Given this list of marker genes HS6ST1, TMSB10, INTS8 (integrator complex subunit 8), TBC1D24, JPT1, HSPE1, MORF4L2, MAGOHB, ABHD5, NUPR1, AIG1, NOL8, ENSG00000267053, MSI2, ZBTB7A, DUSP8, TRIM3, VCAN, TIPRL (TOR signaling pathway regulator), CDK2, SMG1, LYN, BASP1, DONSON, ZNF587, E2F3, FGFR1OP2, WNK1, TM2D1, HMBOX1, SPP1, NFATC1, KMT5B, GSCAR (NCBI Gene Id 124901024), RBM39, CHORDC1, ATXN2, ADD1 (NCBI Gene Id 118), ACSM3, DENND11, NPIPB3, ESR2, PDP1, GRAMD4, ITPR1, FOLH1 (folate hydrolase 1), HERC2P3, RNF149, NECAP2, MALAT1, TALAM1 (NCBI Gene Id 109136579), OSBP2, FAR2P2, BTNL9 (butyrophilin like 9), ZNF621, PPP2R5C, NEAT1, FAM83F, CNTLN, AGO4, HBA1, BPTF, KLHL28, KMT2C, TARS1, BCL2, DCAF7, PLXNA1, ZNF281, SULT1A2, CDK18, EIF5, HSPA6 (heat shock protein family A (Hsp70) member 6), EP400, NORAD (NCBI Gene Id 647979), CBX4, AK4, UBFD1, DNAJC3, FSCN1, PDK1, MTF2, RIPK2, GABPB1-AS1, CRB2, LINC00680, SFPQ, HBE1, UBE2D3, PRAP1, NUB1, GPR158, RNF216P1, DDIT4, PRLR, KCNJ15, ADAM17, NSD1, TGFBRAP1, IBTK, MTDHP3, EML4, CAMSAP1, NTM, THBS2, NKTR, TPX2, DAZAP1, CSNK1G2, HBB, LSP1P5, EIF1AX, GPATCH2L, TERF1, SLC16A1, COX19, RBBP5, S100A8, RBBP6, NFATC2IP, MAP4K4, PRKAB2, PABPC1 (poly(A) binding protein cytoplasmic 1), LRCH3, ZMYND8, EPB41, SPG11, KMT2E, NGF, NBPF14, HOXC6, ATG4D, LINC01560, DYNC1H1, CBX5, POLR2A, WDFY1, SECISBP2, PGP, FAM30A, ORC6, H3C10, LARP1, DDX17, GNL3L, LINC01823, VEGFA, ADAM10, TRIO, LRRC58, ZFYVE16, ZNF395, PDLIM5, LINC00581, GRB2, CELF1, MPO, AGO2, TAOK1, PRB4, AP2B1, LSMEM1, LONRF2, DXO, GOLT1A, ARHGAP1, SPIN1, HCG18, KCNQ1OT1, CPEB4, AR, SLC7A5 (solute carrier family 7 member 5), PRRC1 (NCBI Gene Id 133619), TMCC1, NCAPH2, FN1, ZFP36L1, P4HA1, PAAF1, RAB6B, FNBP4, TAF1D, FBXO45, RALA, CLDN5, LINC00205, SHPRH, RPL37, ZNF148, ZNF605, CEP63, TYRO3 (NCBI Gene Id 7301), UBE2Z (NCBI Gene Id 65264), HBD, FUS, GSK3B, CDKN2D, ENSG00000278932, PCBP2, HSPA1A, FOXM1, PCDHGB9P, ENTR1, GUSBP14, KANSL1, PAICS, BOD1L1, HES6, G3BP1, SEL1L, UGT2B15, UBE2O, RAB12, here is a description of the gene set: Human Gene Set: CHANDRAN_METASTASIS_UP Genes up-regulated in metastatic tumors from the whole panel of patients with prostate cancer. from publication Chandran UR, Ma C, Dhir R, Bisceglia M, Lyons-Weiler M, Liang W, Michalopoulos G, Becich M, Monzon FA (PMID 17430594) BACKGROUND: Prostate cancer is characterized by heterogeneity in the clinical course that often does not correlate with morphologic features of the tumor. Metastasis reflects the most adverse outcome of prostate cancer, and to date there are no reliable morphologic features or serum biomarkers that can reliably predict which patients are at higher risk of developing metastatic disease. Understanding the differences in the biology of metastatic and organ confined primary tumors is essential for developing new prognostic markers and therapeutic targets. METHODS: Using Affymetrix oligonucleotide arrays, we analyzed gene expression profiles of 24 androgen-ablation resistant metastatic samples obtained from 4 patients and a previously published dataset of 64 primary prostate tumor samples. Differential gene expression was analyzed after removing potentially uninformative stromal genes, addressing the differences in cellular content between primary and metastatic tumors. RESULTS: The metastatic samples are highly heterogenous in expression; however, differential expression analysis shows that genes are upregulated and genes are downregulated at least 2 fold in every patient with metastasis. The expression profile of metastatic samples reveals changes in expression of a unique set of genes representing both the androgen ablation related pathways and other metastasis related gene networks such as cell adhesion, bone remodelling and cell cycle. The differentially expressed genes include metabolic enzymes, transcription factors such as Forkhead Box M1 (FoxM1) and cell adhesion molecules such as Osteopontin (SPP1). CONCLUSION: We hypothesize that these genes have a role in the biology of metastatic disease and that they represent potential therapeutic targets for prostate cancer. species: Homo sapiens